The following is a description of a gene set: Genes predicted to be targets of miRBase v22 microRNA hsa-miR-6815-5p in miRDB v6.0 with MirTarget v4 prediction scores > 80 (high confidence targets). from publication Chen Y, Wang X (PMID 31504780) species: Homo sapiens Human Gene Set: MIR6815_5P, and this is the list of marker genes: PRKCI, STXBP3, UNC13D, ARFGEF2, DCUN1D4, RNF125, PLEKHM3, DCX, ZNF124, TOR1B, MED12L, PALLD, CHD5, CAMTA1, ATXN7, VSIG10L, PTGFRN, GOLM1, ZNF367, ZC2HC1B, TBP, DNAJB6, PIANP, BBOF1, FADS1, DLG1, GCH1, RAB43, EPHB1, AK9, CPEB2 (NCBI Gene Id 285549), MYO9A (NCBI Gene Id 80251), IFT57, GALNT4, PSMB5, VGLL3 (vestigial like family member 3), GLO1, ATP10B, FAM76B, ISY1-RAB43, ABR, XKR9, POC1B-GALNT4, DUOXA1, NIP7, ZNF214, CA7, FLT3, TMEM52B, SNCAIP, SPECC1, UBL4A, ZSWIM5, ATP9A, RAB10, IDH1, CCDC25